Given this list of marker genes SOCS5, TWSG1, CD274, ANXA1, TARM1, CBLB, VSIR, ZC3H12A, XCL1, IL4R, CBFB, BCL6, CD69, HMGB1, ZBTB7B, LGALS9, LGALS1, TNFSF18, ASCL2, LGALS9C, LGALS9B, ARG2, JAK3, NDFIP1, ITCH (itchy E3 ubiquitin protein ligase), RUNX3, TNFSF4, RUNX1, RC3H2, HLX, RC3H1, STAT5A, FOXP3, LOXL3, IL2, SMAD7, TBX21, here is a description of the gene set: Human Gene Set: GOBP_NEGATIVE_REGULATION_OF_CD4_POSITIVE_ALPHA_BETA_T_CELL_ACTIVATION Any process that stops, prevents or reduces the frequency, rate or extent of CD4-positive, alpha-beta T cell activation. studied in species Homo sapiens